The following is a description of a gene set: Human Gene Set: GOBP_EPITHELIAL_CELL_PROLIFERATION The multiplication or reproduction of epithelial cells, resulting in the expansion of a cell population. Epithelial cells make up the epithelium, the covering of internal and external surfaces of the body, including the lining of vessels and other small cavities. It consists of cells joined by small amounts of cementing substances. studied in species Homo sapiens, and this is the list of marker genes: ACVRL1, HTR2B, NEAT1, PEX2, FA2H, OR51E2, MIR15B, TGFBR1, ID2, RAF1, TGFA, PYGO2, PPARD, NUPR1, FGF7, PPP1R16B, NCF1, MIR342, CCL5, SIX1, POLD4, SP1, VEGFA, F3, SDR16C5, IRF6, ATP5IF1, TP63 (tumor protein p63), SULF2, NKX2-6, MAP2K5, WNT16, CDC42, NKX2-5, FLCN, YAP1, NRARP, MAP2K2, CASK, MIR92A1, GHRL, TBX2, HMX2, TACR1, MIR29A, CYBA, BMPR1A, HMGA2, NRAS (NCBI Gene Id 4893), PRKDC, DLL4 (delta like canonical Notch ligand 4), BTK, ODAM, MIR23A, STAT3, RPS6KA1, MIR15A, UHRF1, IGF2, KLK8, ANGPTL8, SLURP1, EXTL3, NME2, TNMD, CYP7B1, PTN, PLCG1, STK11, SCARB1, CXCL12, ZNF580, FGFR1, SIDT2, GATA6, OSR1, IHH, SCN5A, MMP14, GATA3, NLRC3, MIR24-1 (microRNA 24-1), WDR13, C1orf54, SIRT1, NKX2-3, FGF10, FABP7, NME1, TBX1, TRIM24, AGTR1, GPR15LG, NOX5, CFLAR, CAV1, SERPINB5, A4GNT, NRP1, BTBD10, CCL11, CRNN, TGFB2, HGF, RB1, KDR, INTU, TGM1 (NCBI Gene Id 7051), VASH2 (NCBI Gene Id 79805), IRS2, AKT1, SOX11, PDGFB, PROK2, CD109, STAT1, SAAL1, JUN, REG3A, SPARC, KDF1, KDM5B, LAMC1, MIR487B, ACVR2A, EFNB2, NODAL (NCBI Gene Id 8114), MTSS1, MIR29B1, BMP6 (NCBI Gene Id 7964), GPBAR1, ERBB2, MIR483, ARNT, WNT5A, CD34 (CD34 molecule), TEK, ITGA4, DLX6, KIT, NF1, KLF9, STAT6, MIR16-1, LIPA, RGCC, SFN, VDR, NGFR, PDX1, RAP1GAP, SMAD3, ISL1, HMOX1, FBXW7, DAB2, SFRP2, BMP5, RBPJ, IFT57, IFT74, CCND1, CCL26, FOXE3, EPPK1, HRAS, KRT4, PURA, NR2F2, CEACAM1, STXBP4, VEGFC, ESR1, ANGPT4, KRIT1, PRKD1, MIR497, FERMT1, APELA, MYDGF, ECM1, ESRP2, HSF1, STK3, PRDM1, FGF1, ITGB3BP, LIMS1, TIE1, HMGB1, HLX, LRG1, MIR133B, MIR30B, IGFBP4, MIR101-1, IFT52, CCL2, BMP4, NFKBIZ, TNFSF11, DAB2IP, RPTOR, CDKN2A, IL26, AGGF1, EGFR, ATP5F1A, CXCR3, PTPRK, LGR5, B4GALT1, MIR30E, MAP2K1, BGLAP, HSPG2, WDR48, GPC3, NCSTN, PIK3CB, HAS2, JCAD, MTA3, SCAND3, EDNRB, NOD2, CALCA, TGFB1, PDCL3, CDK6, FUT2, LEP, FLT4, HIF1A, COL4A3, MARVELD3, MIR130A, MMP12, MYC, ZFP36L1, EPGN, MIR98, ARX, ALOX5, REG3G, SIX4, HES1, RTN4 (reticulon 4), MIR200C, NRP2, BMPR2 (NCBI Gene Id 659), CDKN1C, KRT2, PAX2 (NCBI Gene Id 5076), LIMS2, IGF1, EYA1, DACH1, MIR205, PIK3CD, SCG2, OSR2, ZEB2, PDPK1, MIR20B, DLX5, MIR27A (NCBI Gene Id 407018), IL12B, COL8A2, MIR222, JAG1, TCF7L2, HMGB2, MAGED1, PHOX2B, FSHR, MIR495, AKT3, MIR21, ZNF703, CDK4, DRD2, MIR193A, APLN, RREB1, PDCD6, FGF16, FUT1 (fucosyltransferase 1 (H blood group)), PRKX, OVOL2, FZD7, CDH3, SRSF6, BCL2L2, MMRN2, TACSTD2, DUSP10, PTPRN, CCR3 (C-C motif chemokine receptor 3), MIR149, PTPRM, FAP, MIR129-1, PLXNB3, IL10, EGR3, ERBB4, IL17A, EPB41L4B, ST8SIA1, SIRT6, CDKN2B, HNF1B (NCBI Gene Id 6928), PHB2, SULF1, NUS1, SERPINB1, FSHB, TFAP2C (transcription factor AP-2 gamma), MYCN, RAB33B, FST, LAMB1, GATA2, GDF2, DEAF1, ANG, MIR152, DSC1, IL12A, GDF5 (NCBI Gene Id 8200), LAMA5, STAT5A, ANGPT1, MIR329-1, AQP11, APOA1, GHSR, MIR492, VASH1, WNT10B, CDH13, SAV1, HOXA5, BID, MIR22, SMO, EAF2, SFRP1, VSTM4, ADAM17, CEBPB, VEGFB, HMGN1, GPX1, RUNX2, CDKN1B, BTRC, ERRFI1, CTNNB1, MIR10A, SLC39A9, MIR181C, STK4, APOH, NKX2-8, FLT1, TNF, NOTCH1, AREG (amphiregulin), HES5, MDK, TNFAIP3, APLNR (apelin receptor), RETNLB, IGFBP5, WNT3A, ITGB3, WNT7A, PRL, EPHA2, MAPK1, JAML, NOG, MIR29C (NCBI Gene Id 407026), FAM3C (FAM3 metabolism regulating signaling molecule C), FMC1, SERPINF1, RICTOR, FGF2, THBS4, HDAC6, ALDH1A2, MIR132, IFT80, SHH, NKX6-1, MIRLET7B, NOTCH2, NR1D1, LOXL2, LGR4, PSEN1, BAX, TINF2, MIR499A, FGFBP1, EMC10, C6orf89, CDC73, MIR10B (NCBI Gene Id 406903), MIR146A, B2M, RUNX3, SEMA5A, NR4A1, ERBB3, CCL24, PRKD2, BAK1, BCL2L1, PDCD10, MIR150, CLEC12B, PGR, XBP1, PKHD1, ZFP36, ENG, ZEB1, ITGB1BP1, THAP1, EREG, WDR77, BCL11B, MIR424, PROX1, ROBO1, BRCA2, IL6, IGFBP3, MCC, MIR126, C5AR1, FGFR2, MED1, MIR125B1, FOXP2, PROK1, SNAI2, CLDN18, MIR135B, PPARG, ERN1, CLDN1, HPN, THBS1, TGFBR3, BAD, WNT2, MIR503, FGF18, FRS2, ZNF304, EGF, BMPER, NFIB, PTCH1 (NCBI Gene Id 8015), OVOL1, AIMP1, CAV2, CDKN1A, ATOH8, IFT172, CCN3, APOE, GLI1, RASGRF1, PAX6, IQGAP3, MIR26A1, SOX9, MEF2C, SYNJ2BP, MIR34A, FGL1, LACRT, DLG1, TNFSF12, GRN, CNMD, NR4A3, MIR27B (microRNA 27b), MIR361, MIR410, TMIGD1, MIR494, MIR2355, AR (NCBI Gene Id 367), NKX3-1, PRKCA, FGF9, SGPP2, EGFL7, DBH, COL8A1